The following is a description of a gene set: from publication Xie X, Lu J, Kulbokas EJ, Golub TR, Mootha V, Lindblad-Toh K, Lander ES, Kellis M (PMID 15735639) Comprehensive identification of all functional elements encoded in the human genome is a fundamental need in biomedical research. Here, we present a comparative analysis of the human, mouse, rat and dog genomes to create a systematic catalogue of common regulatory motifs in promoters and 3' untranslated regions (3' UTRs). The promoter analysis yields 174 candidate motifs, including most previously known transcription-factor binding sites and 105 new motifs. The 3'-UTR analysis yields 106 motifs likely to be involved in post-transcriptional regulation. Nearly one-half are associated with microRNAs (miRNAs), leading to the discovery of many new miRNA genes and their likely target genes. Our results suggest that previous estimates of the number of human miRNA genes were low, and that miRNAs regulate at least 20% of human genes. The overall results provide a systematic view of gene regulation in the human, which will be refined as additional mammalian genomes become available. Genes having at least one occurrence of the highly conserved motif M33 YTATTTTNR in the regions spanning 4 kb centered on their transcription starting sites. This matches the MEF2A transcription factor binding site V$MEF2_02 (v7.4 TRANSFAC). species: Homo sapiens Human Gene Set: YTATTTTNR_MEF2_02, and this is the list of marker genes: BANP, HAS2, ATOH7, HSF2, TM4SF20, LEAP2, MAB21L1, ACMSD, ATXN1, P2RY12, STC1 (stanniocalcin 1), PPP2R2A, DMP1, CCP110, GBX2, TP63, NLK, PPARGC1A, IPO4, PIP4K2B, ITSN1, LYPD1, NDST2, ADAM11, DOCK8-AS1, HS3ST5, MORC1, SOX1, MYOZ2, PPM1B, ESRRB, SH3TC2, RAB20, KMT2E, ATP6V1A, MAP1A, FOS, LOX, KLF14, CREB5, DEPP1, HNRNPL, MAL2, TMSB10, DUSP10, SLITRK1, MPG, ARAP2, CSNK1A1L (casein kinase 1 alpha 1 like), SLC2A4, GRIK1, INO80D, FBXO40, PVALB, PPFIA2, GRIA3, BMP7, MXI1 (MAX interactor 1, dimerization protein), FEZF2, ANKRD28, MLF1, POLR2C, XIRP1, FBXL22, ETV1, SH2D1A, SLC8A3, BDNF, KCNN1, CTNNA1 (catenin alpha 1), PPP1R16B, TMEM67, TFB1M, RPH3A, AAK1, MYH10, ARHGEF37, BIRC8, KCNG3, SLC12A8, MBNL2, KLF3, RIMS2, MAX, NEXN-AS1, TGFB3, FOXP2, PGAP1, RAP2C, NREP (NCBI Gene Id 9315), PTGR3, SIPA1L1 (signal induced proliferation associated 1 like 1), ZBTB18, GRIN2B, MUSK (NCBI Gene Id 4593), SREK1, LINC03122, RNF17, PRUNE1, S100PBP, F13A1, JCHAIN, SI, GRIK2, ZSCAN20, CDK2AP1, IL25, SIAH3, AMMECR1, CPT1B, ARL6IP5 (NCBI Gene Id 10550), HIPK3, INPPL1, HIPK1, DYNC1I1, CTNND1, ANKRD44, ZFHX3, TRIP10, LHX4, KIF13A, LRP2BP, MARCHF3, FXR1, SDHC, GRM8, SMARCAL1, PHEX, ERLIN1, RRS1, ITGBL1, RWDD3, KRTAP13-1, GNAO1, RNF207, SLC14A1, PRRX1, ADAM23, SEMA6A, MYH6, CAST, FGF10, SIPA1, TSSK1B, PCMTD1, PLCD4, DOCK8, RNF24, EPHA3 (EPH receptor A3), KTN1, GYG1, SSPN, TNNC2, SPTB, MARK1 (microtubule affinity regulating kinase 1), SLMAP, PDGFRA, CXCL1, PPM1E (NCBI Gene Id 22843), LRP5, ADAMTS12, MCF2, TLL1, LINC00310, PPTC7 (protein phosphatase targeting COQ7), CFAP54, KLF3-AS1, GRK7, NRXN3, ADHFE1, DRD3, TNNT1, NR4A1, NOL4, RAB33A, VAMP3, COX6A2, SPATA6L, RAB21, CHD2, NRIP1, PEX5, NAA50, PRKAA2, RNF146, STARD6, SCML1, SEMA4D, TNNI3K, ANP32CP, TMEM127, ZNF35, SLCO5A1, MORC4, PROKR2, RFX3, KCNA3, CTR9, NRDE2, CA7, TPP2 (NCBI Gene Id 7174), CLIC5, KLF15, CASQ1, VXN, CARMIL1, CUX1, B3GNT5, USP25, ANO1, IL1RAPL1, LINC00472, MED13, CRACDL, STAG2, MBIP, SOX4 (NCBI Gene Id 6659), GPR174, MID2, BRAF, ATP5ME, ZFPM2, OMG, SGCD, MINDY2, LAMB2, SYT4, CNBP, SLN, NT5C1A, TFB2M, PRDM1, SP3, CTSK, ERG, ARMCX4, KCNMB4, TCEAL9, PTCHD4, ARHGAP36, STAC3, FGF13, RGL1, NDEL1, HS6ST2, GNAS, MTMR12, FGF12, MB, HOXA2, BARX2, SBF2, CRTAP, CASK, PLAGL1, CARTPT, MIA2, CAPN3, FLRT3, NDP, RTL3, PLAGL2, TMEM38A, ARPC5, E2F3, RETREG1, DSG1, MMP14, PALLD, YWHAG, EEF1A2 (eukaryotic translation elongation factor 1 alpha 2), MAP4K5, MAML3, SERPINB10, MEOX2, RNF148, PRKAR2B, COL1A2, ATP2C1, MGLL, RBM14, ENPP1, ANP32D, NCAM1, CNTF, HES1, WAC, TRIM33, SP7, TNNC1, GOLT1B, CYLC2, SP4 (Sp4 transcription factor), VANGL1, CNTLN, ITGA7, GPR34, HDAC4, SIRPA, TPBG, JOSD2, JAZF1, GPER1, IER5L, PDLIM5, MYL5, NTS, TNNT2, PNMA1, LRRC4, NFIB (NCBI Gene Id 4781), COPS3, KCNJ11 (NCBI Gene Id 3767), YARS1, TRIM14, IL22, ASPH, HOXB5, BCL2L11, MYL1, SGCB, TNNI2, WIPI1, CDKN2A, HPGD, IAPP, CD180, IPO13, TSC1, HOXA3, MLLT6, PRELID3A, SCUBE3, DTNB, TLE4, ARRDC3, INTS9, SHH (sonic hedgehog signaling molecule), IGSF9B, KYNU, CRYAB, HJV, NFIX, GRIN2D, PABIR3, ELMO3 (engulfment and cell motility 3), HBP1, PI15, MAFA, NEURL2 (NCBI Gene Id 140825), KRTAP4-5, MAB21L2, RGS1, TNFSF13, GPR27, ENPP2, DACT1, AKAP10, MIEF2, ANGPT2, TMEM60, EPHX4, RASAL2, ADCYAP1 (adenylate cyclase activating polypeptide 1), ASB11, SALL3, PPOX, LAMA2, SLC12A5, DCSTAMP, ORC4, CAT, PCDHA6, SLC25A34, CNST, SLC16A13, LRCH2, MOSMO, LMNA, HOXA5, HSPB2, UBALD2, ZC3H11A, ARHGEF15, GPR158, SLC35C2, C1orf43, FGF6, EPN2, BICDL1, GABRR2, CDKL5, FITM1, ZIC5, CDC42EP3, PARP1 (NCBI Gene Id 142), FBXO11, JSRP1, GABRA1, TLR7, LINC00474, MYO9A, KCNN3, PCDH9, LINC01089, FABP4 (fatty acid binding protein 4), BCL11A, ESAM, TMEM182, ARK2N, DNAJC3, ARHGAP26, GARRE1, PCDHGA1, TMEM108, SSRP1, EYA1, CPA2, EPN1, RAG2, COL8A1, OPCML, STK26, MAP2K5, KY, CHN1, MYPN, TTN (titin), MSL3, PSMA8, ASB2, SCOC, AFF4, KCNIP2, ZNFX1, FOXP1, CARNMT1, TNFSF10 (NCBI Gene Id 8743), PTPN22, ZDHHC22, OBSCN, TMEM88, CTSA (cathepsin A), UNC45B, CSRNP3, TIMP2, TMOD4, ST6GALNAC5, UBE2D1, ADAMTS14 (ADAM metallopeptidase with thrombospondin type 1 motif 14), RESF1, JADE1 (NCBI Gene Id 79960), LZTS2, RTN4RL1, COG6, IGFBP1, RALY, FXYD1, ZFAND5, GP9 (NCBI Gene Id 2815), MLLT3, LSM14B, DIP2B, DTNA, MED24, ELF4, SPC25, SYNE1, PLAAT1, FGFBP2, GPR52, CITED4, EBF1, TSC22D1, NDRG3, KLF5, IP6K2, DZIP1L, PHOX2B, CIAO1, RASGRF1, PACS1, CKMT2, KLB, HMBOX1, DENND2C, HNF4G, FAM110D, USP13, ZNF516-DT, OFCC1, UBXN10, SIX6, SLC26A6, IL6R, ACTC1, HOXB6, IRAK1, KLF12, PPP1R10, DMD, TMPRSS11F, JMJD1C, RPP21, GCAT, SCG3, TFAP2A, PPARA, SNAP25, YJEFN3, KCNJ1, BMAL1, C2CD2L, NCAN, NEIL3, GNG11 (NCBI Gene Id 2791), BHLHE40, SHKBP1, SIK2, SNX7, KCNA7, PANK1, PTPN1, RFX4 (regulatory factor X4), NFIA, ZNF362, AQP7, PPP2R3A, ID2, SMARCA2, ITGA10, GADD45B, CFAP299, SIK3, CSRP3, TMEM117, SERPINB7, JPH2, TNNI1, RHBDL3, KCNJ9, FRMD5, SLC7A8, GLG1, P4HA1, SGCG (sarcoglycan gamma), AICDA, HOXA10, PHF20L1, FNBP1, DLL4, CELA3A, RECQL, HNRNPA0, CLASP1, MYL3, CDKN1A, SLC39A13 (solute carrier family 39 member 13), HOXD4, USP2, HMGN2P46, PRMT3, MAML1, DLGAP4, STRADB, AKIRIN2, ETS1, DNAJB2, ZRSR2, PPM1A, TBC1D32, TWIST1, ZHX2, EEF1AKMT1, CCND1, MYOCD, DBH, CREB1, JUN, HDAC9, FAM107B, TRHR, ELAVL4, EDN1, CASQ2, PHKA2, PACSIN3, SOX2, TRDN, BOLL, TLK1, KCND3, CKM, ACVR2A, FOSB, ESRRG, LGI1, LAT2, VPS45, ZDHHC5, OMD, NEK2, CCN2 (cellular communication network factor 2), LRTM1, PCNX1, CLDN14, NR6A1, CLEC1B, ZNF281 (zinc finger protein 281), RBFOX1, PGAM2, PDGFA, C10orf71, TMEM71, AGTPBP1, POFUT1, SLC30A4, SOBP, ARPC5L (actin related protein 2/3 complex subunit 5 like), SLC12A1, TOP1, ZNF385B, CCDC14, TSSK3, ATOH1, DLG2, HS3ST1 (NCBI Gene Id 9957), NFAT5, GNB4, SESTD1, PCSK1, ANKS1B, CDC27, ROGDI, NTNG2, CD34, RHOQ, NAB2, CUL3, WFDC1, CTHRC1, CEBPB, AMER1, BMPR2, ADGRB3, MYL2, RNF43, CLDN12, ERO1B, TRAK2, DPY19L2P2, ASB7, EML4, USP28, RBM12B, STBD1, CACNA2D3, FOXJ3 (NCBI Gene Id 22887), XK, NBEA, MITF, NRP2, PHF3, MYL11, KAT6B, PWWP3B, PDZRN4, IL10, MBD3L1, HSD11B1, PPP1R3A, GPLD1, PBX3, LINC01555, JUNB, PDCD4, CNTN2, NR3C2, LIFR, AK8, ATL3, PPM1L, TBR1, DGKB, MRPS18B, LIX1, NPNT, TSSK2, GTF3C3, CDH19, ZBTB37, SLC44A5, SPACA9, RFFL, GARIN6, MSL2, PTPN21, ANGPTL7 (angiopoietin like 7), FRMD4A, ASB15, LRRC8C, LMO3, HLX, GATA4, DMPK, PRDX5, DGKI, NEDD4, BCL6, MPP7, SMPX (small muscle protein X-linked), CNTNAP4, LYN, TRMT112 (tRNA methyltransferase activator subunit 11-2), C1orf21